The following is a description of a gene set: Human Gene Set: GOMF_MITOCHONDRION_TARGETING_SEQUENCE_BINDING Binding to a mitochondrion targeting sequence, a specific peptide sequence that acts as a signal to localize the protein within the mitochondrion. species: Homo sapiens, and this is the list of marker genes: TOMM22, TOMM70, TOMM20, TOMM20L, TIMM22